The following is a description of a gene set: studied in species Homo sapiens Human Gene Set: GOCC_SPERM_HEAD_TAIL_COUPLING_APPARATUS A centrosome-based structure consisting of two cylindrical microtubule-based centrioles and associated components which anchors the flagellum to the sperm head., and this is the list of marker genes: PMFBP1, CCDC146, DNAJB13, IFT88, FSIP2, CNTLN, SUN5, PRKAR1A, CCDC42, SPATA6L, SPATA6, CAPZB, CEP131, SPATC1L, AKAP4, CCDC159, CFAP47